The following is a description of a gene set: from publication Cui A, Huang T, Li S, Ma A, Pérez JL, Sander C, Keskin DB, Wu CJ, Fraenkel E, Hacohen N (PMID 38057668) Mouse Gene Set: CUI_CDC1_IL27_RESPONSE_UP species: Mus musculus Genes positively differentially expressed in cell type: cDC1 (conventional dendritic cell type 1) upon treatment with cytokine: IL-27 in mouse lymph nodes in vivo. Cytokines mediate cell-cell communication in the immune system and represent important therapeutic targets. A myriad of studies have highlighted their central role in immune function, yet we lack a global view of the cellular responses of each immune cell type to each cytokine. To address this gap, the authors created the Immune Dictionary, a compendium of single-cell transcriptomic profiles of more than 17 immune cell types in response to each of 86 cytokines (>1,400 cytokine-cell type combinations) in mouse lymph nodes in vivo. A cytokine-centric view of the dictionary revealed that most cytokines induce highly cell-type-specific responses. For example, the inflammatory cytokine interleukin-1β induces distinct gene programmes in almost every cell type. A cell-type-centric view of the dictionary identified more than 66 cytokine-driven cellular polarization states across immune cell types, including previously uncharacterized states such as an interleukin-18-induced polyfunctional natural killer cell state., and this is the list of marker genes: Tspo, Irf7, Pfn1, Ewsr1, Txn1, Acadl